The following is a description of a gene set: Human Gene Set: GOBP_RIBOSOME_DISASSEMBLY The disaggregation of a ribosome into its constituent components; includes the dissociation of ribosomal subunits. studied in species Homo sapiens, and this is the list of marker genes: ELAC1, MTRES1, RCHY1, DENR, MTIF2, RNF25, SKIC3, GFM2, PELO, DDRGK1, ZNF598 (NCBI Gene Id 90850), MRPL58, SKIC8, ABCE1, USP10, EIF2D, GIGYF2, EIF4E2, RNF14, MTIF3, RACK1, MRRF, MCTS1, MTRFR, TRIP4, UFSP2, PTRH1 (peptidyl-tRNA hydrolase 1 homolog), HBS1L, GTPBP2, UFL1, CDK5RAP3, ASCC3, TCF25, GCN1, SAYSD1, ASCC2, SKIC2, TRNT1, LTN1, ANKZF1, NEMF, KLHDC10